Given this list of marker genes Inpp5a, Sesn2, Ncl, Zfp592, Samd11 (NCBI Gene Id 231004), Epb41l2, Epha4, Lonp1, Lsm4 (LSM4 homolog, U6 small nuclear RNA and mRNA degradation associated), here is a description of the gene set: Mouse Gene Set: GOMF_PH_DOMAIN_BINDING species: Mus musculus Binding to a PH domain (pleckstrin homology) of a protein, a domain of about 100 residues that occurs in a wide range of proteins involved in intracellular signaling or as constituents of the cytoskeleton.